The following is a description of a gene set: studied in species Mus musculus Mouse Gene Set: GOBP_VESICLE_DOCKING The initial attachment of a transport vesicle membrane to the target membrane, mediated by proteins protruding from the membrane of the vesicle and the target membrane. Docking requires only that the two membranes come close enough for these proteins to interact and adhere., and this is the list of marker genes: Stx3, Stx1a, Exoc8, Ncam1, Exoc3 (exocyst complex component 3), Tprg1l, Exoc2, Exoc6, Stx8, Rims2, Ykt6, Vps11, Stx1b, Stx5a, Stx16 (syntaxin 16), Stx12, Stxbp2, Ppfia3, Bloc1s6, Stxbp3 (NCBI Gene Id 20912), Gnao1, Unc13c, Exoc1, Rims1, Ralb, Cep83, Kcnb1, Vps18, Uso1, Stxbp1, Unc13b, Exoc6b, Unc13a, Ndrg4, Stx11, Syt1, Exoc7, Cav2, Sytl2, Stx6, Vamp2, Rims3, Cftr, Rab8a, Exoc4, Plek, Stx4a, Septin5, Exoc5, Bves, Camk2a, Cln3, Stx2, Ctbp2 (NCBI Gene Id 52060), Stx19, Stx17, Syde1, Stx7